Given this list of marker genes ZMYND10, DNAAF11, DNAAF6, DNAAF5, CCDC103, DNAH1 (NCBI Gene Id 25981), CFAP100 (cilia and flagella associated protein 100), CCDC40, DNAAF2, DNAI3, DNAAF4, DNAH2, DNAH7, CCDC39, TEKT2, CFAP73 (NCBI Gene Id 387885), DNAAF1, here is a description of the gene set: Human Gene Set: GOBP_INNER_DYNEIN_ARM_ASSEMBLY The aggregation, arrangement and bonding together of a set of components to form an axonemal dynein inner arm, an inner arm structure present on the outer doublet microtubules of ciliary and flagellar axonemes. studied in species Homo sapiens